The following is a description of a gene set: studied in species Homo sapiens The forkhead O transcription factors (FOXO) integrate a range of extracellular signals including growth factor signaling, inflammation, oxidative stress and nutrient availability, to substantially alter the program of gene expression and modulate cell survival, cell cycle progression, and many cell-type specific responses yet to be unraveled. Naive antigen-specific CD8+ T cells undergo a rapid expansion and arming of effector function within days of pathogen exposure, but in addition, by the peak of expansion, they form precursors to memory T cells capable of self-renewal and indefinite survival. We used microarrays to determine whether FOXO1 broadly affects effector and memory differentiation, and to what extent FOXO1 determines the program of memory T cell gene expression. from publication Hess Michelini R, Doedens AL, Goldrath AW, Hedrick SM (PMID 23712431) Genes up-regulated during acute viral infection in KLRG1 low CD8 T cells: wildtype versus FOXO1 knockout. Human Gene Set: GSE46025_WT_VS_FOXO1_KO_KLRG1_LOW_CD8_EFFECTOR_TCELL_UP, and this is the list of marker genes: CALU, HIF3A, VTI1A, ARRDC2, ACO2, RAC3 (Rac family small GTPase 3), HLA-E, STX4, MS4A2, PDIA5, EFHD2, EIF3LP3, ADAMTS3, FPR2, SLC14A1, TWIST2, BSCL2, FOXP2, KRTAP4-1, WNT8A, EDDM3B, VWA7, SLCO4A1, GHRL, REXO1L1P, DNAH17, MT3, EMC1, CEP72, MKRN7P (makorin ring finger protein 7, pseudogene), VASN, CCDC162P, PTGIS, TYSND1, SERPINF1, CA2, TOB1-AS1, NUP210, CYP4F30P, TBC1D14, CD2BP2, GPATCH3, PLCB3, CRK, HSD3B1, PYCR1, LAMTOR1, ZBTB1, NNMT, H6PD, LCAT, ALKAL2, ARRB2 (NCBI Gene Id 409), OR13C4, PIGH, FAM47C, SLCO1B3, GSEC, HRH1, ULK1, SLIT2, PLOD3, ADAM23, CCDC9, CISH, ECEL1, FBXO40, GLYATL2, PIEZO1, OTOS, BCOR, GBP6, OSGEP, WNT7B, NR2F2 (nuclear receptor subfamily 2 group F member 2), PDK4, LSM2, YRDC, TMEM203, PIP5K1A, ZBTB7C-AS2, RAMP1, SLC12A5, SELENBP1, TEAD4, TMEM120A, TNFSF14, EFHC2, RGS16, MGARP, RNF182, RCC2, PTOV1, GNA15, RGS10, CEP85, FPR3, OCM2, APBB3, ZDHHC18, WDR59, RALY, ATP5F1D, YIF1A, TYK2, HOXA4 (homeobox A4), CLPB, LSR, MOCS1, KRT19P2, TUBA1B, IGF1, EPCAM, THEMIS, WDFY3, FAM228A, CDH12, SLC33A1, PLCXD1, TAT, HK1, CMTM2, MYCNOS, LINC01619, FHOD1 (NCBI Gene Id 29109), COLGALT1, GEMIN5, CNIH2, DYNLT5, SPHK1, HNRNPAB, KLF7, TGM2, TES, S1PR5, ZCWPW2, COX6A2, PMPCA, RPL22, RAF1, PES1, TAB1 (NCBI Gene Id 10454), COMTD1, PKDREJ, DSG3, TUBB3, UCK2, FAM43B, NDUFB2, RPS19BP1, SLC18A3, CASC3 (CASC3 exon junction complex subunit), ST6GALNAC6, MAF1, ZNF558, LYL1, TOX4, TNFRSF25, SLC1A2, PRR14, CLK3, MAB21L4, TPTE2P1, IP6K1, ALYREF, FRRS1, CHST5, CTSA, GNPTG, CFAP92, LINC01096, LINC01122, GLOD5, MPST, NUDC, TMEM219, RASGRF1, TRPM7 (NCBI Gene Id 54822), DDX56, GFOD2 (Gfo/Idh/MocA-like oxidoreductase domain containing 2), TLR4, AURKAIP1, ZNF598, OR52K3P, SH3BP2, MMRN2, ERP27, AKAP8L, TTLL9, SRM, TEX14, CRB1, AGPAT4, FAM110C (family with sequence similarity 110 member C), SULT1E1